Given this list of marker genes Paip1, Pabpc1, Hnrnpd, Csde1, Syncrip (NCBI Gene Id 78260), here is a description of the gene set: Mouse Gene Set: GOCC_MCRD_MEDIATED_MRNA_STABILITY_COMPLEX A protein complex that binds to, and promotes stabilization of, mRNA molecules containing the major coding region instability determinant (mCRD) by bridging the mCRD domain and the poly(A) tail of the mRNA. In human, it consists of CSDE1, HNRPD, PABPC1, PAIP1 and SYNCRIP. species: Mus musculus